The following is a description of a gene set: studied in species Mus musculus Mouse Gene Set: GOBP_RESPONSE_TO_OSMOTIC_STRESS Any process that results in a change in state or activity of a cell or an organism (in terms of movement, secretion, enzyme production, gene expression, etc.) as a result of a stimulus indicating an increase or decrease in the concentration of solutes outside the organism or cell., and this is the list of marker genes: Scn2a, Scn7a, Lrrc8c, Agt, Mir29b-2, Stk39, Slc12a6, Ryr1, Kcnma1, Rcsd1, Nlk, Lrrc8a, Serpinb6c, Slc4a11, Serpinb6a, Tspo, Pycard, Capn3 (calpain 3), Pck1, Trpv3, Clcn2, Mir99a, Aqp5, Akr1b1, Dysf, Mir451a, Mir9-3, Aqp1, Casp1, Lrrc8d, Anxa7, Vps13a, Xrcc6, Nlrp3, Itga2, Cln3, Mknk1, Tsc22d3, Kmo, Serpinb6b, Mir137, Map7, Prkg2, Gypa, Trp53, Serpinb6e (NCBI Gene Id 435350), Plk3, D1Pas1, Pkd2, Rac1, Mir29c, Mir7b, Slc12a2, Tifab, Pdpk1, Sst, Hnmt, Agtr1b, Tsc22d4, Bad, Usp15, Mtor, Mir434, Micu1, Bdkrb2, Mir30b, Fbp1 (fructose bisphosphatase 1), Xrcc5, Epo, Mir204, Zfp36l1, Bax, Mlc1, Serpinb6d, Slc12a5, Tsc22d2, Slc2a4, Relb, Wnk3, Mir9-1, Mlst8, Nedd4l, Oxsr1, Lrrc8e, Efhd1, Rptor, Mir100, Abcb1a, Slc2a1, Pkn1 (protein kinase N1), Hsp90aa1, Ninj1, Abcb1b, Trpv4, Mir9-2 (NCBI Gene Id 723967), Map2k7, Agtr1a, Vac14, Slc25a23, Ddx3x, Mir29b-1, Mylk, Wnk1, Ptgs2, Ptk2b, Casp3, Th, Marveld3, Ybx3, Atf2 (activating transcription factor 2), Letm1, Atp1a1, Ang, Mapk13